Given this list of marker genes MZT2B, MFSD2A, GATA6 (NCBI Gene Id 2627), EIF1AY (NCBI Gene Id 9086), TMEM141, DCBLD2, ANXA3 (NCBI Gene Id 306), MARCHF3, IL1R1, PIM1, COL5A2, IL1RAP, PRDX6, CD74, COL1A1, CTDNEP1, TMEM70, HRH1, RPS10, TNFSF13B, RPS2, ISOC2, PTMA, SELENOH, B4GALT5, TUBA1C, CNKSR3, FCER1G, RPL12, CCL7 (C-C motif chemokine ligand 7), RPL11, RPL29, AP1S1, SET, NCOA7, GAS1, ZNF330, TUBB3, RNF145, CD47, MMD, KPNA2, SNRPG, STMP1 (short transmembrane mitochondrial protein 1), CXADR, TPT1, NDUFA3, RAB13, MRPL36, CDK5RAP2, ABRACL, HSPD1, RGS17, BACH1, LXN, WWC1, RPL37, BCL3, CISD1, PTPRF, HLA-DRB1, GNG5, MPHOSPH6, IER5 (immediate early response 5, NCBI Gene Id 51278), RPL26, RBP1, TMEM219 (transmembrane protein 219), EPGN, TSPO, UPK3B, FDCSP, SOD2, PRDX5, SRP19, TRAPPC1, LRP2, TMEM160, FKBP11, TMEM258, PDXK, AREG, APOL2, GCHFR, DAPK1, OSTC, AQP3, GMFB, PPP1R15B, ARL4A, ALOX5AP, BMP2, PGLS, FOXC1, HLA-DPA1, STEAP1, RPLP2, HP, EIF4EBP1, UBA52, PSME2, TGFB1, GAP43, CD55, RPS15A, SPTSSA, DUSP23, OLA1, COX7C, UROD, VAPA, BYSL, RPS20, CXCL6, DUSP6, HIGD2A, FAAP20, RAB31, CALB2, COX6B1, RBP4, ERP29, TFPI2, ERGIC3, HLA-B, NHERF1, TOMM22, PHPT1, ATOX1, MELTF, IFI30, BICC1, IFI27, CRLS1, SNRPF, PLA2G2A, NQO1, UBE2L6, CD200, ERRFI1, C1orf162 (NCBI Gene Id 128346), NICOL1, MZT2A, ENO1, ADAMTS9, SNRPE, SLC12A8, BDKRB1, CFI, RPS27A, MRTO4 (MRT4 homolog, ribosome maturation factor), PDLIM4, AP2S1, FAM153CP (NCBI Gene Id 653316), ARPC1B, TMEM165, RPS3, LY6E, SNRPD1, TGM1, CENPW, CNIH1, TMEM98, FLNC, KLK8, FIS1 (NCBI Gene Id 51024), RPL28, SLC39A8, UGP2, APRT, RPL35, CFB, ANP32B, RPL35A, RPL7, ITLN1, NME1, HLA-F, PGM2, TIMP1, MAP4K4, HLA-DQB1, MTCH2, KRT10, PLAAT3, CCNG1, UBE2S, TNFSF14, PTRHD1, RPL39, NCL, HEG1, MT1E, NECTIN3, MAF, BAX, RPL13A, ALKBH7, WT1, EIF3A, CLDN15, KLK11, MT1F (NCBI Gene Id 4494), MEST, MCUB, PLA2G12A, NOP10, UAP1, IL6ST, TXNL4B, STAP2, ASPHD1, RPS6, PSMB9, DKK1, RPL22L1, LSM5, GJA1, LGALS1, RPSA2, MT1X, RPS14, ATP5MC2, MRPL11, UGDH, C2, CITED4, VTN, LYZ, S100A6, BNC2, RPL7A, RPL9, RPL32, RPS13, SLC16A1, ATP2B1, POLR2I, NAMPT, RPL37A, MEIS2, CASP4, RPLP1, MRPS21, RPL23, ECT2 (epithelial cell transforming 2), SULF1, HLA-DRB6, NPM1, TCTN1, NHP2, ZFAS1, TMEM134, SLC7A8, EFNA1, RPS5, ELOC, C19orf33, MARCKSL1, KIF21A, FAM174C, RPS15, SYCE1L, TRAPPC5, RPS17, TUBB2A, GGCT, MST1, BNC1, SGK1 (NCBI Gene Id 6446), CTTN, FAM110C, RPS3A, TIMM17A, SERP1, IFT25, UQCR11, METAP2, GCSH, SDC4, MIF, TMEM132A, LETM1, ATP6V0E1, UGCG, GMPR, ILF2, DYNLT1, NDUFA1, MIR4435-2HG, PPA2, C1QA, HSPE1, LSR, FAM20A, PTGER3, LINC01133, OCIAD2, LRATD2, TJP2, GCLM, AK6, RPL10, VAMP8, ABCA1, HMGN1, HK2, RPS18, TRAF4, ZNHIT1, FDXR, TPBG, COTL1, NDUFAF8, KTN1, ARAP2, COL3A1, ENY2, RPL36A, C1QB, KRT5, RPLP0, PHGDH, MRPL23, MGAT4B, CCDC80, TNNT1, TIMM8B, ARHGAP23, COX17, EIF3M, LGALS2, GPX1, HIF1A, SH3BGRL3, TFRC, SERPINB2, SLC20A1, SULF2, S100A16, SH3BP5, PAIP1, MAST4, MUC16, CADM3 (NCBI Gene Id 57863), UQCRQ, PYCARD, PLOD2, EPHB6, SEC11A, PDZK1IP1, ANKRD28, FABP5 (NCBI Gene Id 92424), SERPINB4 (NCBI Gene Id 6318), CKS2, THBS2, PPP1R14B, DSC3, RPL18, C1QC, POLD4, CTNNAL1, ATP5F1E, PAFAH1B3, MRPL51, FGG, FKBP1A, CLIC3, C3, RPL17, PLAAT4, CA12, RPL4, JPT1, PTGFRN, PAPPA, RPS12, PRG4, KLF5, RPL31, RRP1, UQCRB, PLIN2, MRPS33, NMI, EMB, RPS28, TNFRSF12A, RPS21, CLNS1A, APOC1, GALNT9, DHCR24, RPL27, HLA-DRB5, MEDAG, RPS27L, STMN1, EVA1C, IGFL2, OSR1, CYRIB, RPL8, ST3GAL5, CD7, LRRC59, UXT, THAP9-AS1, SIPA1L2 (signal induced proliferation associated 1 like 2), RAB7B, RPL38, FABP4, FMO1, MGARP, GAPDH, UBE2D1, RPS27, OGN, NONO, UQCRH, PTGS1, RPL10A, H19, PRDX3, CNIH4, DECR1, TYMP, PRKCI, GMPPA, EFNB2, METRN, HMGN3, RPS19, BTF3L4, GTF2I, HLA-DRA, BBLN, LAP3, PLSCR1, IGFBP1, TIMM9, DAB2 (DAB adaptor protein 2), TMEM176A, EEF1B2, RMDN1, MRPL41, NPC2, MYL6B, MYRF, ALDH1A3, TIMM13, MT1L, RPL18A, F2RL1, RAI1, MT1G, PPA1, TMSB4X, RDH10, TP53TG1, WFDC2, DMKN, RPL14, CLDN1, TRAPPC6A, GOLM1, LHFPL2, TRAPPC2L, ODC1, SLIRP, KCNK1, CCDC71L, NENF, PRSS23, TXN, TAF10, TM4SF1, POLR2L, RPS9, FST, MICOS10 (mitochondrial contact site and cristae organizing system subunit 10), PSMB8, RPS24, DSP, CHI3L1 (chitinase 3 like 1), PROCR, IFI16, RPL23A, EBPL, GFPT2, RARRES1, DDX21, CIB1, MT2A, MFAP2, TMEM14C, FBL, RPL13AP5, RPS4Y1, CPA4, ZMAT3, BACE1 (NCBI Gene Id 23621), COX4I1, KDELR3, DPYSL3, DSG2, CBX3, STAT1, CASP2, STXBP2, PSMA2, TMEM256, ATP5MJ, SMOX, GAS5, CRB2, RPS25, SERPINE1, ZNF593, HLA-DQA1, RPLP0P2, HAS1, HDLBP, CYP27A1, TMEM91, ATP5MF, RPL13, MARCO, NSG1, SERPINA1, MT1H, VCAM1, AKR1A1, NDUFA7, TXNDC17, TSTD1, WARS1, RPL34, GNG11, KLF16, TPM3 (tropomyosin 3), TYROBP (NCBI Gene Id 7305), AADAC, FBXO2, MRPL14, CYB5A, RPA3, RPL27A, GALNT1, UBE2L3, PODXL (NCBI Gene Id 5420), DUSP4, RPL36, SLC18B1, IGFBP4, SF3B5, HLA-DMA, REC8, PHLDA2, RGS4, SYNCRIP, RAMP2, MAN2B1, PKP2, NDUFB2, C19orf53, NNMT, KRT8, CCNYL1, RPL41, RPSA, ARPC5L, CHP1, SSR4, IL20, APOA1, SNHG29 (NCBI Gene Id 125144), NDUFB5, RPL19, PTGIS, RBBP8, MGST1, SH3GLB1, MSLN, SQOR, HINT1, HSD17B6, NOP16, TGIF1 (TGFB induced factor homeobox 1), SNHG5, KRT19, TMED3, ARL6IP1, B4GALT1, RGS10, TOMM5, NACA2, IGBP1, KRT18, RPS11, FLNB, IL18, TCEAL9, TMEM14B, KDR (kinase insert domain receptor), GSTK1 (NCBI Gene Id 51064), TNFRSF21, S100A10, GTF3C6, RPS23, HNRNPAB, CDH2, RPS8, SAT1, CLTC, MRPL12, SLPI, HPCAL1, TMSB10, RPS29, SEC61G, ACSL4, IFITM1, ELOVL5, CAPG, LY96, CUTA, TP53I3, CPXM1, MPST, UPK1B, HLA-DPB1, PDPN, TMOD3, HS2ST1, SCP2, B2M, RNF149, CCDC25, HDAC2, ARF6, SCO2, FXYD5, ATP13A3, UROS, SCAND1, MSANTD3, SPSB1 (NCBI Gene Id 80176), PPIL1, EEF1G, here is a description of the gene set: species: Homo sapiens from publication Travaglini KJ, Nabhan AN, Penland L, Sinha R, Gillich A, Sit RV, Chang S, Conley SD, Mori Y, Seita J, Berry GJ, Shrager JB, Metzger RJ, Kuo CS, Neff N, Weissman IL, Quake SR, Krasnow MA (PMID 33208946) Human Gene Set: TRAVAGLINI_LUNG_MESOTHELIAL_CELL